Given this list of marker genes USP36, TNFAIP3, PSD, CCL4, ERCC6, PPP1R14D, RGS16, DUSP5, MIR615, REL, HNRNPH3, RGS4, SPAG9, CD69, RPH3A, MYOC, SEMA6A, HTRA4, MFSD2A, TNFRSF4, PER1, FGFR1, PLAU (plasminogen activator, urokinase), KATNA1, CDKN1A, ADORA2A, PNMA1, CHAC1, PTCHD1, ZC3H12A, EGR3, STAP2, TFRC (NCBI Gene Id 7037), HRH3, TSC22D2, GRIK2, ZFPL1, CBR3, BAIAP2, ADH4 (NCBI Gene Id 127), FGD3, RND3 (NCBI Gene Id 390), CPEB2, PMFBP1, EHD1, KRTAP26-1, ATG16L2, CYP2E1, AEN, CNGB3, SH2D2A (SH2 domain containing 2A), CYP24A1, HTR2C, IL2 (NCBI Gene Id 3558), TNF, ORAI1, RRAD, VPS37B, PKD1L1, TRAF2, FNIP1, PTPRR, GABRA4, PLAAT5, CARS1, KPNA7 (karyopherin subunit alpha 7), RAMP3, FANCC, ADAM28, EGR1, MIR185, DGAT1, APTX, SLC7A1, IRAK2, CXCL10, VGLL2, MS4A12, FLRT3, TET2, ADORA2B, EGR2, TBXT, NR4A3, MYBPC3, SLC38A2, TMTC3, ITK, SGMS2, OSBPL10, RUNDC1, CHKA, TNIP2, ANKRD61, TGIF1, LIF, PLSCR2, CRABP2, EMD, SLC3A2, NFKBIZ, CSRP1, CEACAM19, DUSP4, PPP1R16B, TRIB3, LSG1, FBXW9, URM1, CDK11B, MAL, ZFAND2A, BDKRB1, PRRG4, MIR23A, TMEM52, OTOG, AGO4, KDM6B, CHD2, HNRNPH1, BACH1 (BTB domain and CNC homolog 1), WFIKKN1, SIK1, CCR8, SPESP1, SMOX, MAP2K3, UTF1, DUSP16, TNFRSF25, DKK2, MIR31, PLK3, KRT76 (NCBI Gene Id 51350), TTC19, NRL, LRATD2, SPIN4, ZMYND12, PMEPA1, SAFB2, MYO10, ELP1, TNFSF11, SDAD1, ISY1, BAX, GADD45B, GARS1, CD274, CREM, TRAF1, LITAF, here is a description of the gene set: from publication Indraccolo S, Pfeffer U, Minuzzo S, Esposito G, Roni V, Mandruzzato S, Ferrari N, Anfosso L, Dell'Eva R, Noonan DM, Chieco-Bianchi L, Albini A, Amadori A (PMID 17202376) IFNs are highly pleiotropic cytokines also endowed with marked anti-angiogenic activity. In this study, the mRNA expression profiles of endothelial cells (EC) exposed in vitro to IFN-alpha, IFN-beta, or IFN-gamma were determined. We found that in HUVEC as well as in other EC types genes were upregulated (>2-fold increase) by IFNs, including genes involved in the host response to RNA viruses, inflammation, and apoptosis. Interestingly, genes showed a >5-fold higher induction by IFN-alpha in EC compared to human fibroblasts; among them, the gene encoding the angiostatic chemokine CXCL11 was selectively induced by IFN-alpha in EC along with other genes associated with angiogenesis regulation, including CXCL10, TRAIL, and guanylate binding protein 1 (GBP-1). These transcriptional changes were confirmed and extended by quantitative PCR analysis and ELISA; whereas IFN-alpha and IFN-beta exerted virtually identical effects on transcriptome modulation, a differential gene regulation by type I and type II IFN emerged, especially as far as quantitative aspects were concerned. In vivo, IFN-alpha-producing tumors over-expressed murine CXCL10-11, GBP-1 and TRAIL, with evidence of CXCL11 production by tumor-associated EC. Overall, these findings improve our understanding of the anti-angiogenic effects of IFNs by showing that these cytokines trigger an anti-angiogenic transcriptional program in EC. Moreover, we suggest that quantitative differences in the magnitude of the transcriptional activation of IFNresponsive genes could form the basis for cell-specific transcriptional signatures. Human Gene Set: GSE3920_UNTREATED_VS_IFNG_TREATED_ENDOTHELIAL_CELL_UP species: Homo sapiens Genes up-regulated in endothelial cells: untreated versus IFNG.